The following is a description of a gene set: species: Homo sapiens Human Gene Set: GOBP_PROTEIN_TRIMERIZATION The formation of a protein trimer, a macromolecular structure consisting of three noncovalently associated identical or nonidentical subunits., and this is the list of marker genes: MIF, P2RX7, STEAP4, ALOX5AP, CD74, SLC1A5, MLKL, PNPT1, PXDN, CLYBL, SLC1A2, SIGMAR1, COL1A2, P2RX3, ITLN1, APP, HLA-G, SCARA5